Given this list of marker genes PRDM1, ENSG00000275173, WDR86-AS1, VMP1, CDK7, RN7SKP9 (NCBI Gene Id 100873853), LINC01765, FAM117A, LPCAT2, NF1 (NCBI Gene Id 646021), CDC14A, PLAAT2, RSBN1, ATP5MJ, PPME1, LINC01934, POU2F1, DESI1, LINC01259, SERPINI1, SUOX, SLC25A46, AKAP13, LINC02564, LINC02404, PSMB10, PTK2, ADAM33, REV3L, CEP128, TRBV6-5, ARHGAP26, RPS19BP1, SINHCAF, MANF, HROB, YARS1, TMBIM1, SDCBP2-AS1, TRIM34, LILRB1, MTCO3P47, CNTRL, PCF11, GRM7, NIBAN1 (NCBI Gene Id 63911), MTSS1, TNRC6B, PARAIL, LINC00652, GRAMD2B, TSPAN14, IL16, LERFS, ERICH3, ENSG00000265222, IGF2BP2, CHMP1B, INPP5D, MRTFA, TLR3, PARP8, BUB1B-PAK6, RIPOR2, PRKACB, SNX25P1, OR2W3, ALPK1, IQCF2, SNX5, TBC1D1, ENTPD6 (ectonucleoside triphosphate diphosphohydrolase 6), SUFU, SRPK2, ACTR6, VPS8, TTN-AS1, IFNG-AS1, LCDR, SLC25A29, U2AF1L4, DLG1, NUGGC (NCBI Gene Id 389643), NAV1, UMOD, LINC01825, ESRRG (estrogen related receptor gamma), ENSG00000238387, BTN3A1, IGHV3-35, PSENEN, UTP20, B4GALT4, KLHL6, MIR4437, C1orf74, LINC02642, EEF1E1P1, ATF7IP, KDM2A, RSL24D1, SRBD1, ABRACL, NRXN2, TBL1XR1, MIR5194, IFI16, ZNF451, JMJD1C, CPEB3, UBR1, LZTFL1, SEMA6A, MTHFD1L, RPL17P2, KAT7, CALCOCO2, CHSY1, RNU1-62P, LINC00607, CEACAMP3, RNF7, BCDIN3D, CNTNAP2, TRMT61B, PTPRO, CFAP418, C2CD3, ST3GAL1, CCDC186, TRAPPC3L, ARL14EP, BUB1B, WEE1, CD28, TTLL5, LNCATV, SLC9A9, CTSS, ORC2, here is a description of the gene set: Human Gene Set: TERF2_TARGET_GENES Genes containing one or more binding sites for (TERF2) in their promoter regions (TSS -1000,+100 bp) as identified by GTRD version 20.06 ChIP-seq harmonization. studied in species Homo sapiens from publication Yevshin I, Sharipov R, Kolmykov S, Kondrakhin Y, Kolpakov F (PMID 30445619)